The following is a description of a gene set: Human Gene Set: BOSCO_INTERFERON_INDUCED_ANTIVIRAL_MODULE from publication Bosco A, Ehteshami S, Stern DA, Martinez FD (PMID 20336062) Asthma exacerbations are associated with subsequent deficits in lung function. Here, we tested the hypothesis that a specific pattern of inflammatory responses during acute exacerbations may be associated with chronic airway obstruction. Gene coexpression networks were characterized in induced sputum obtained during an acute exacerbation, from asthmatic children with or without chronic airflow limitation. The data showed that activation of Th1-like/cytotoxic and interferon signaling pathways during acute exacerbations was decreased in asthmatic children with deficits in baseline lung function. These associations were independent of the identification of picornaviruses in nasal secretions or the use of medications at the time of the exacerbation. Th2-related pathways were also detected in the responses, but variations in these pathways were not related to chronic airways obstruction. Our findings show that decreased activation of Th1-like/cytotoxic and interferon pathways is a hallmark of acute exacerbation responses in asthmatic children with evidence of chronic airways obstruction. Genes representing interferon-induced antiviral module in sputum during asthma exacerbations. species: Homo sapiens, and this is the list of marker genes: TRIM22, CD274, OAS3, GCH1, PANK2, EIF2AK2, SLAMF7, DHX58, MS4A6A, SDC3, PTPN2, GOLGA4, PML, IFI6, IFIT5, PRAF2, IFIH1, TMEM106A, IFIT3, IFI35, TMEM176A, NOD1, OAS2, CCL2, CDK1, RIN2, ITGA4, UBE2Z, SAMD9L, SLC39A8, MX1, IFITM3, PARP12, PNPT1, TNFSF10, DDX60, IFIT1, APOL6, OASL, LAMP3 (NCBI Gene Id 27074), MOV10, TRAFD1 (NCBI Gene Id 10906), LINC01128, TTYH2, RSAD2, LRRC37A11P, KPTN, IRF7, APOBEC3G, IFI44, GBP4, GBP7, MYO1G, IFI44L, HERC5, CYP24A1, STAT2, SLC25A28, MIA3, ST3GAL5, CGAS, P2RY14, CMTR1, CD40, EPSTI1, LILRB1, APOL1, TNIP3, LAT, ZBP1, NCOA7, NUB1, ANXA2R-OT1, XAF1, AVPR2, CD80, ARAP2, TDRD7